The following is a description of a gene set: Human Gene Set: GOBP_REGULATION_OF_GLUTAMATE_SECRETION_NEUROTRANSMISSION species: Homo sapiens Any process that modulates the frequency, rate or extent of glutamate secretion, neurotransmission., and this is the list of marker genes: KMO, STXBP1, SLC38A2, DTNBP1, RAB3GAP1